The following is a description of a gene set: Mutations in the heterodimerization domain (HD) and PEST domain of NOTCH1 are frequently found in cis in T-cell acute lymphoblastic leukemia. While HD mutations alone result in up to ~10-fold increase in NOTCH1 transcriptional activity and PEST domain mutations alone result in up to ~2-fold increase in NOTCH1 transcriptional activity, in cis mutations of HD and PEST domains act synergistically, increasing NOTCH1 transcriptional activity up to ~40-fold. studied in species Homo sapiens Reactome Pathway: Signaling by NOTCH1 HD+PEST Domain Mutants in Cancer part of: Signaling by NOTCH1 in Cancer, and this is the list of marker genes: ADAM17, NEURL1, MIB1, APH1A, KAT2A, HDAC2, PSENEN (NCBI Gene Id 94939), HDAC3, NEURL1B, CREBBP, HEYL, DLL4, KAT2B, TBL1X, MAML2, NCOR1 (nuclear receptor corepressor 1), HES1, CUL1, UBB, HDAC7, UBA52, JAG1, HDAC4, MIB2, SKP1, JAG2, PSEN1, NOTCH1, ADAM10, APH1B, DLL1, RBPJ, MAML1, CDK8, NCOR2, HEY2 (NCBI Gene Id 30830), HES5, EP300, HDAC6, FBXW7, MAML3, SNW1, RPS27A, MYC, MAMLD1, HDAC11, RBX1, HDAC5, HEY1, NCSTN, HDAC9, HDAC1, UBC, PSEN2, HDAC8, TBL1XR1, CCNC, HDAC10